The following is a description of a gene set: species: Mus musculus from publication Motenko H, Neuhauser SB, O'Keefe M, Richardson JE (PMID 26092688) Mouse genes annotated to increased granulosa cell tumor incidence (MP:0012411) retrieved from the Mouse Genome Informatics database via MouseMine Mouse Gene Set: MP_INCREASED_GRANULOSA_CELL_TUMOR_INCIDENCE, and this is the list of marker genes: Helq, Ctnnb1, Bap1, Msh5, Pten, Fancf, Atad5, Bin1, Apc